The following is a description of a gene set: species: Homo sapiens Human Gene Set: KEGG_MEDICUS_REFERENCE_MODIFYING_OF_CONDENSIN_I_SUBUNITS Modifying of condensin I subunits. Pathway ID: N01500. Pathway type: Reference. Pathway class: nt06512 Chromosome cohesion and segregation. Pathway Definition from KEGG: AURKB,CDK1 -- NCAPD2,NCAPG,NCAPH, and this is the list of marker genes: NCAPD2, NCAPH, NCAPG, CDK1, AURKB